Given this list of marker genes RACGAP1, PCGF5, PPIB, CAB39L, FEZ2, IFITM10, TSPAN31, DAP, KLRK1, CPT2, LEF1, WTAP, SRPK1, SEPTIN6, CIB1, HNRNPAB, HIKESHI, ATP5PO, SETD6, RNF14, UBQLN1, LY6H, LAMTOR4, HCLS1, MACROH2A1, RORA, RNF167, CMAS, KLRD1, ARFRP1, DHRS1, RNPS1, EIF2B5, KLK8, GIT1, EBNA1BP2, BLVRA, ANAPC16, SNX1, ORC5, XPNPEP1, HSD11B1, ITGAX, ARL4C (ADP ribosylation factor like GTPase 4C), MBP, DCPS, RMC1, LYSMD1, CSRP3, PRKCH, SLC1A5, SMPD1, PRIM2 (NCBI Gene Id 5558), EIF6, CTSD, GPC1, PSMB3, SCP2, EFTUD2, ITGB7, MTSS2, ANXA6, VAV1, TWF2, DPM2, FGFR3, PTPN6, LDAH, USP22, LAMTOR5, ACP5, BNIP3L, PLAC8, TIMM44, B4GALT1, CDC37, ANXA1, EIF2B4, PKP3, PNPO, SSNA1, PHTF1, BCKDK, KCNJ8, ATP6V0C, LSM1, PRPSAP1, JKAMP, ZIK1 (NCBI Gene Id 284307), GRAMD2B, CCR2, CTSA, PIK3CD, UBE2H, LGALS9B, HIPK1, ABCA2, ETS1, AP1M1, DUS1L, ITGAL, REPS1 (NCBI Gene Id 85021), AXIN1 (NCBI Gene Id 8312), BRAP, MTMR1, FAM117A, GSTT2, NDUFB6, CCNDBP1, TBCB, ENTPD4, TMEM147, PDIA6, ST13, GCAT, HERPUD1, TXNL4A, CORO1B, USP5, FAM89B, RSU1, MFNG, DCTN5, SELENOH, TMC6, LSM4, GOLM1, HMCES, SEMA4A, BSCL2, SATB1, C8orf33, RAD17, EIF3L, DYM, RPP25L, RABGGTA, CDKN2D, SMIM20, AK3, TMEM208, ISYNA1, YIPF3, DBI, TIAM1, PTTG1, IL17RA, DGKA, CALU, GLIPR2, NSMCE1, DNAJB1, PSMB2, STK38, WARS1, KLRC1, SWAP70, FHL2, MTCH1, PIM2, PALD1, MLX, TMEM223, HADHB, DNM1, TMEM45A, MRPL34, EIF3B, DDX41, ELAVL1, ATP6V0B (NCBI Gene Id 533), EIF4A3, PSMD13, CHFR, RPN1, DPEP1, TUBA3C, SLC66A2, LRWD1, ZFYVE19, IL18RAP, PRKAG1, ANAPC5, MKNK2, PLD3, UBE2Z, MIEN1, KIAA2013, AURKAIP1, SRP68, GDAP2, COMMD7, ICAM2, EIF2S1, CMTM7, RPS6KA4, KLRG1, FCGR2B, PPIF, DEAF1, here is a description of the gene set: CD8 T cells normally differentiate from resting naïve T cells into function effector and then memory CD8 T cells following acute infections. During chronic viral infections, however, virus-specific CD8 T cells often become exhausted. We used microarrays to examine the gene expression differences between naive, effector, memory and exhausted virus-specific CD8 T cells following lymphocytic choriomeningitis virus infection. studied in species Homo sapiens Human Gene Set: GSE9650_EFFECTOR_VS_EXHAUSTED_CD8_TCELL_UP Genes up-regulated in comparison of effector CD8 T cells versus exhausted CD8 T cells. from publication Wherry EJ, Ha SJ, Kaech SM, Haining WN, Sarkar S, Kalia V, Subramaniam S, Blattman JN, Barber DL, Ahmed R (PMID 17950003)